Given this list of marker genes RPS23, EIF4A1, EIF3M, EIF4G1, RPS27L, EIF3B, RPS20, RPSA, RPS2, EIF4H, EIF3E, RPS25, FAU, RPS14, RPS15, RPS4Y1, EIF2S3, EIF2S1, RPS28, 18S rRNA, RPS27, EIF4A2, EIF3I, EIF2S2, EIF3J, RPS19, RPS15A, EIF4B, EIF4EBP1, EIF3A, RPS8, EIF3G, EIF3C, RPS5, EIF3F, RPS9, EIF3H, RPS7, RPS4X, EIF4E, RPS3A, EIF3K, EIF3L, RPS29, PABPC1, RPS24, RPS17, RPS26, RPS16, RPS11, EIF1AX, RPS18, RPS10, RPS21, RPS27A, EIF3D, RPS13, RPS4Y2, RPS6 (NCBI Gene Id 92956), RPS3, RPS12, here is a description of the gene set: part of: Cap-dependent Translation Initiation The cap-binding complex is constituted by the initiation factors eIF4A, eIF4G and eIF4E. First, eIF4E must be released from the inactive eIF4E:4E-BP complex. Then eIF4A interacts with eIF4G, and eIF4E binds to the amino-terminal domain of eIF4G, resulting in the formation of the cap-binding complex eIF4F. eIF4A together with eIF4B or eIF4H is thought to unwind RNA secondary structures near the 5'-end of the mRNA. The translation initiation complex is formed when the 43S complex binds the cap-bound mRNA. Reactome Pathway: Activation of the mRNA upon binding of the cap-binding complex and eIFs, and subsequent binding to 43S species: Homo sapiens